The following is a description of a gene set: Human Gene Set: HP_PORPHYRINURIA Porphyrinuria species: Homo sapiens Abnormally increased excretion of porphyrins in the urine., and this is the list of marker genes: CPOX, PPOX, GATA1, SLCO1B1, HMBS, SLCO1B3, UROS, UROD